Given this list of marker genes ATP2B1, COX5A, GPALPP1, FAM120A, TFDP2, CORO1C, ELL2, POGK, ERICH5, TAF7L, ZDHHC17, TMEM132E-DT, PTCD3 (pentatricopeptide repeat domain 3), SPTY2D1, MGAM2, ZBTB43, NEMP2, ZBTB14, SOS2, IRF2BP2, NR2F2, GET1-SH3BGR, RGPD1, NECAB1, C5orf47, DLD, CETN1, NRIP1, PHF13, SLC10A1, PTH2R, RFX3, ME1, MINDY2, TBX18, ENTPD1, TMA16, MLH3, SDR42E1, NTN4, FAF1, EFCAB7, RANBP9, SH3BGR, RC3H1, RAD51AP1, SERPINB9, ZBTB41, TPGS2, MTMR4, FGFR1, SIRT5, PNPLA1, MRPS9, KCNMB4, PIGA, PTGFRN, ACTR2, ARHGAP17, MCC, MATR3 (NCBI Gene Id 9782), B3GALT1, CLASP2, CYLD, PTPRG, here is a description of the gene set: from publication Chen Y, Wang X (PMID 31504780) Human Gene Set: MIR562 studied in species Homo sapiens Genes predicted to be targets of miRBase v22 microRNA hsa-miR-562 in miRDB v6.0 with MirTarget v4 prediction scores > 80 (high confidence targets).